The following is a description of a gene set: studied in species Homo sapiens Binds to and increases the activity of adenylate cyclase. Human Gene Set: GOMF_ADENYLATE_CYCLASE_ACTIVATOR_ACTIVITY, and this is the list of marker genes: GNAS, CALM2, CALM3, RAF1, CALM1